The following is a description of a gene set: species: Homo sapiens Any process that stops, prevents or reduces the frequency, rate or extent of chromosome organization. Human Gene Set: GOBP_NEGATIVE_REGULATION_OF_CHROMOSOME_ORGANIZATION, and this is the list of marker genes: BIRC5, NDC80, ZNF207, PRAP1, CDCA8, HNRNPA1, GNL3L, CCNB1, SPC25, SETMAR, XRN1, PLK1, BUB1B, SLX1B, MCRS1, ERCC4, CDC20, H3-3A, SLX4, HNRNPC, SRC, NUF2 (NCBI Gene Id 83540), TRIP13, GEN1, CTC1, TINF2, AURKB (NCBI Gene Id 9212), PIF1, POT1, ACD, TENT4B (terminal nucleotidyltransferase 4B), SMARCA5 (NCBI Gene Id 8467), NBN, BAZ1B, BUB1, DCP2, RTEL1, DYNC1LI1, ZWILCH, SLX1A, MAD2L1BP, PML, TNKS2, HASPIN, MAD2L1, ZWINT, STN1, H3-3B, KNL1, CDK5RAP2, USP44, PARP3, HNRNPU, SKA1, CENPF, KNTC1, ERCC1, SPC24, PARP1, IK, TTK, MAD2L2, DUSP1, KLHL22, TEX14 (testis expressed 14, intercellular bridge forming factor), ZW10, TNKS, ESPL1, TERF2 (NCBI Gene Id 7014), WAPL, TEN1, APC, RAD21, TPR, RAD50, SKA3, PRP4K, ATRX, TP53, NAA10, XRCC3 (X-ray repair cross complementing 3), ANAPC15, TERF1, XRCC1, MAD1L1, SMG6, ATM, LCMT1, PSMG2, FBXO5, EXOSC10, INCENP, BUB3, PINX1, SPDL1, NAT10, TERF2IP